Given this list of marker genes Ndn, Nnmt, Brms1, Sirt1, Ncor2, Fnta (NCBI Gene Id 14272), Ifng, here is a description of the gene set: species: Mus musculus Any process that increases the rate, frequency, or extent of protein deacetylation, the removal of an acetyl group from a protein amino acid. An acetyl group is CH3CO-, derived from acetic acid. Mouse Gene Set: GOBP_POSITIVE_REGULATION_OF_PROTEIN_DEACETYLATION